The following is a description of a gene set: species: Homo sapiens Assembly or disassembly of microtubules by the addition or removal of tubulin heterodimers from a microtubule. Human Gene Set: GOBP_MICROTUBULE_POLYMERIZATION_OR_DEPOLYMERIZATION, and this is the list of marker genes: MID1IP1, KIF14, ARHGEF7, TUBG1, SLAIN2, HAUS2, EML2, TRPV4, MAP6D1, STMN3, GOLGA2, PRUNE1, GAS2L1, PCNT, TUBGCP2, HAUS6, MAPT, TUBGCP4, GBA2, CLIP1, CLIP3, FBXO5, PIN1, KIF2B, CKAP5, PSRC1, AKAP9, BLOC1S2, SPEF1, CDKN1B, CDK5R1, HAUS3, RAC1, HAUS7, TAOK1, KIF2C, GAS2L2, TUBB4A, SLAIN1, KIF24, KIF2A (NCBI Gene Id 3796), HDAC6, TOGARAM1, WDR47, ANKRD53, RPS3, CDH5, NDEL1, NCKAP5, ARHGEF2, NME7, MET, CAMSAP2 (NCBI Gene Id 23271), CCDC88C, STMND1, CSNK1D, SNCA, MAP4, KATNB1, HAUS8, NDE1, CLASP2, STMN1, RANBP9, TTBK2, CAV3, TPPP, HSPA1B, DYRK1A, MAP1S, SPECC1L, PPP2CB, OCLN, KIF18B, TUBG2, KIF18A, SKA3, HDGFL3, DIAPH3, KIF19, NAV3, STMN4, CDK5RAP2 (CDK5 regulatory subunit associated protein 2), STMN2, CCSAP, DRG1, TUBGCP3, MECP2, DCTN1, MAP1B, CAMSAP3 (calmodulin regulated spectrin associated protein family member 3), ABL1, FES, BMERB1, SSNA1, BBOF1, MAP2, CCDC66, APC, TBCD (tubulin folding cofactor D), NIN, FKBP4, TUBGCP6, TPX2, MAP1A, TPPP3, HSPA1A, CIB1, CEP192, CCDC57, CENPJ, TRIM54, NEDD1, CLASP1, SKA1, MAP7D3, ARL2, TUBB1, HAUS4, MZT1, MAPRE3, MID1, CRYAB (crystallin alpha B), ZNF207, NUMA1, SLC39A12, GIT1, HAUS5, PAK1, CAMSAP1, CKAP2, MAPRE1, TUBA1A, KIF21A, TUBGCP5, PDE4DIP, MAPRE2, SPAST, APC2, TPPP2, PPP2CA, NCKAP5L, INPP5J, HAUS1, FGF13, AURKB, SKA2 (NCBI Gene Id 348235), ATXN7